Given this list of marker genes C1D (NCBI Gene Id 10438), SP1, CTDP1, H2AX, WRN, SNRNP200, HSP90AA1, RPA1, TP53, POU2F1, POLR2A, DCLRE1C, SRF, IGHG1, XRCC4, MYC, PARP1, here is a description of the gene set: Human Gene Set: COLLIS_PRKDC_SUBSTRATES from publication Collis SJ, DeWeese TL, Jeggo PA, Parker AR (PMID 15592499) Double-strand breaks (DSBs) arise endogenously during normal cellular processes and exogenously by genotoxic agents such as ionizing radiation (IR). DSBs are one of the most severe types of DNA damage, which if left unrepaired are lethal to the cell. Several different DNA repair pathways combat DSBs, with nonhomologous end-joining (NHEJ) being one of the most important in mammalian cells. Competent NHEJ catalyses repair of DSBs by joining together and ligating two free DNA ends of little homology (microhomology) or DNA ends of no homology. The core components of mammalian NHEJ are the catalytic subunit of DNA protein kinase (DNA-PK(cs)), Ku subunits Ku70 and Ku80, Artemis, XRCC4 and DNA ligase IV. DNA-PK is a nuclear serine/threonine protein kinase that comprises a catalytic subunit (DNA-PK(cs)), with the Ku subunits acting as the regulatory element. It has been proposed that DNA-PK is a molecular sensor for DNA damage that enhances the signal via phosphorylation of many downstream targets. The crucial role of DNA-PK in the repair of DSBs is highlighted by the hypersensitivity of DNA-PK(-/-) mice to IR and the high levels of unrepaired DSBs after genotoxic insult. Recently, DNA-PK has emerged as a suitable genetic target for molecular therapeutics such as siRNA, antisense and novel inhibitory small molecules. This review encompasses the recent literature regarding the role of DNA-PK in the protection of genomic stability and focuses on how this knowledge has aided the development of specific DNA-PK inhibitors, via both small molecule and directed molecular targeting techniques. This review promotes the inhibition of DNA-PK as a valid approach to enhance the tumor-cell-killing effects of treatments such as IR. studied in species Homo sapiens Substrates of PRKDC.